Given this list of marker genes Trpc4ap, Selenow, Fscn1, Actn4, Hk1, Rnf126, Dusp10, Ngf, Kdm3a, Lsm2, Cited2, Mpp2, Plod2, Col6a2, Mark2, Cnot3, Carm1, Ppm1g, Slc16a3, Srm, Zfp57, Lbh, Itga5, Ctnnd1, Abcf2, Bcl2l1, Jund, Prss35, Med15, Tle5, Ip6k2, Gprc5a, Mybbp1a, F2rl1, Atn1, here is a description of the gene set: Genes up-regulated by hypoxia in TRAMP-C cells (prostatic cancer) expressing HIF1A and FOXA2 off plasmid vectors. Mouse Gene Set: QI_HYPOXIA_TARGETS_OF_HIF1A_AND_FOXA2 studied in species Mus musculus from publication Qi J, Nakayama K, Cardiff RD, Borowsky AD, Kaul K, Williams R, Krajewski S, Mercola D, Carpenter PM, Bowtell D, Ronai ZA (PMID 20609350) Neuroendocrine (NE) phenotype, seen in >30% of prostate adenocarcinomas (PCa), and NE prostate tumors are implicated in aggressive prostate cancer. Formation of NE prostate tumors in the TRAMP mouse model was suppressed in mice lacking the ubiquitin ligase Siah2, which regulates HIF-1alpha availability. Cooperation between HIF-1alpha and FoxA2, a transcription factor expressed in NE tissue, promotes recruitment of p300 to transactivate select HIF-regulated genes, Hes6, Sox9, and Jmjd1a. These HIF-regulated genes are highly expressed in metastatic PCa and required for hypoxia-mediated NE phenotype, metastasis in PCa, and the formation of NE tumors. Tissue-specific expression of FoxA2 combined with Siah2-dependent HIF-1alpha availability enables a transcriptional program required for NE prostate tumor development and NE phenotype in PCa.